The following is a description of a gene set: studied in species Mus musculus from publication Chen Y, Wang X (PMID 31504780) Mouse Gene Set: MIR_19B_1_5P Genes predicted to be targets of miRBase v22 microRNA mmu_miR_19b_1_5p in miRDB v6.0 with MirTarget v4 prediction scores > 80 (high confidence targets)., and this is the list of marker genes: Slitrk4, Heg1, Tfcp2l1, Rsad1, Ceacam1, Fam120a, F13a1, Fbxo8, Cnot7, Gbe1, Vegfc, Tasor, Arhgap6, Tnrc6a, Ube2r2, Thap11, Cacna2d1, Arpc5, Phf6, Ednrb, Il23r, Nkain3, Zfp623, Sel1l, Ano3, Ddx5, Il33, Eif4g2, Tbx3, Scarf1 (NCBI Gene Id 385602), Hsf2bp, Spred2, Foxb1, Etl4, Rgmb, Arl13b, Slamf1, Hoxa2, Xiap, Gcnt1, Cggbp1, Pramel3b, Lrrc2, Hivep3, Pla2g2d, Fam228a, Igsf3, Slc24a2, Vezt, Tmem127, Cdh2, Ciita, Nav1, Rora, Tmf1, Pdcd6ip, Cfl2, Glul, Srebf1, Sprr2a3, Tub, Zfp65, Dnmt3a, 1810010H24Rik, Rin2, Pdlim5, 1700029H14Rik, Adgre4, Flrt3, Pim1, Rbms3, Pik3r3, Col12a1, Cdcp1, Tmpo, Tmem255a, Cbln2 (NCBI Gene Id 225810), Trpm3, Cyp2j5, Ar, Slc6a8, Dennd1b, Maoa (monoamine oxidase A), Zmym5, Nfatc2, Grk4 (G protein-coupled receptor kinase 4), Tent5a, Ubxn2a, Thsd4, Igf1, Ptprj, Ajap1, Pramel3c, Xkr6, Polr3e, Ccdc127, Il7r, Fgf13, Celsr1, Psmd12, Tob2, Kcnh8, Gabpa, Ube2g2, Kdm4c, Kcnj3, Pip4k2a, Ttr, Armc8 (NCBI Gene Id 74125), Ghr, Rpp14, Grik2 (glutamate receptor, ionotropic, kainate 2 (beta 2)), Zyg11b, Brinp1, Qki, Nrxn1, Edn1, Wwp1, Foxp1, Col3a1, Fam168b, Kcnd2, Stxbp5 (NCBI Gene Id 78808), Dlk1, Phf20, Slc7a7, Arhgap36, Plp1, Mosmo, Fscn3, Bcl11a, Parp16, Ppargc1a, Rbbp7, Tet2, Draxin, Hdgfl3, Ro60, Pik3ca, Agfg1, Onecut2, C130050O18Rik, Elovl6, Garem1, Corin, Palld, Pan2, Dcdc2a, Cers4, Purb, Nipbl, Npat, Nox1, Dhx33, Cdc14b, Zfp704, Lrch2, Ndrg4, Gria2, Commd2, Spcs1, Nkd2